The following is a description of a gene set: Human Gene Set: GSE25123_CTRL_VS_IL4_STIM_MACROPHAGE_DN species: Homo sapiens from publication Szanto A, Balint BL, Nagy ZS, Barta E, Dezso B, Pap A, Szeles L, Poliska S, Oros M, Evans RM, Barak Y, Schwabe J, Nagy L (PMID 21093321) Conditional macrophage-specific PPARg knockout mice were generated on C57Bl/6 background by breeding PPARg fl/- (one allele is floxed, the other is null) and lysozyme Cre transgenic mice. PPARg and IL-4 signaling was analyzed on bone marrow-derived macrophages. Bone marrow of 3 mice per group was isolated and differentiated to macrophages with M-CSF (20 ng/ml). 20 ng/ml IL-4 was used to induce alternative macrophage activation and 1 uM Rosiglitazone (RSG) was used to activate PPARg. From each mouse 4 samples were generated: 1. M-CSF, 2. M-CSF+RSG, 3. IL-4 and 4. IL-4+RSG. All compounds were added throughout the whole differentiation process, and fresh media was added every other day. Control cells were treated with vehicle (DMSO:ethanol). After 10 days, RNA was isolated and gene expression profiles were analyzed using Mouse Genome 430 2.0 microarrays from Affymetrix. Genes down-regulated in wildtype bone marrow-derived macrophages: control versus treated with IL4., and this is the list of marker genes: GPR34, CTNNBIP1, EIF3E, DOCK9, TAB2, CYLD, YWHAE, MYRIP, SPAG1, CSDE1, ZNF296, LINC01016, IMPA2, FURIN, AGAP3, FOXK1, TTC4 (NCBI Gene Id 7268), BANK1, EPHA4, YBX3, CASK, LMNA, IL4R, CABIN1, RXYLT1 (NCBI Gene Id 10329), GPR183, TMEM87B, COPG2, ZFYVE26, ARID4A, PTAR1, ZNF711, TP53I13, SLC2A13, FXYD7, CDCA7, FUCA1, TLR2, NXN, LRRC37A16P, ZZZ3, LTA4H, COX4I1 (cytochrome c oxidase subunit 4I1), BCL2L2, KARS1, RAB5A, GNB4, KIT, PAQR6, SLFN13, RFX3 (NCBI Gene Id 5991), OGT, MBOAT1, TBC1D32, RAB21, RCAN3, LGALS3BP, RPS2, MICAL3, LRRC37B (leucine rich repeat containing 37B), PHLPP1, EIF3H, ADCY3, GOLGA2P5, SESTD1, ZCCHC24, STK17A, MAP3K1, SLC19A2 (solute carrier family 19 member 2), KAT2A, CEP68, EIF2D, TIMP2, FAM167A, PRKAR2B, BHLHE40, PPP3CA, CCNG2, MIER2, TNFSF11, RAD51B, CD27, ENSG00000284837, ADAM9, TCIRG1, CDHR1, ARMCX2, SLC20A1, THAP11, GATA3, C1orf210, ARMT1, ADAMTS14, FBL, HNRNPU, TRRAP, LIMS1, POLR1F, RPE, GPATCH2, HVCN1, NFKB2, IL10RA, IL7R, OSBPL9, ATIC, DPH5, PTK2, LRRFIP1, DST, PLP2, ACAA1, RPL36A, NREP, SCYL1, PRSS33, ANXA7, ANXA2R-AS1, SGSM3, CDK5RAP3, DOCK10, KLHL13, WHAMM, MLXIP, MTM1, PIKFYVE, MAP3K4, QTRT1, FNIP1, REXO5, MYC, JAK2, GRHL1, TSPAN4, SCPEP1, SPRY1, AMPD3, MICALL1, EEF1B2, SPRY2, MAML2, DERA, DUSP4, CENPM, PTEN, SNN, XPC, MACROH2A1, ILDR2, TST, MAP9, SVIL, LARP1B, IER3, C2orf68, ARHGAP21, BRPF1, SLC7A6, KMT2E, USP27X, YWHAG, RPS12, MZF1, MCCC1, MPST, IFTAP, NOD2, ITM2C, ALCAM, GAB1, ASH1L, ZC3H7A, UBE2Q2, INPP1, ITPR1, SH3YL1, RBPJ, HAPLN3, WASHC4, RPL36, DZIP3, DTX1, CMTM6, ESD, PRAM1, ARMCX1, TRAF5, ZNF544, RPSA, RPLP2, NELL2, STX17, AIG1, DOCK7, TSPYL4, UBASH3B, PRMT2, RPS9, USP20